The following is a description of a gene set: Nephrocalcinosis Human Gene Set: HP_NEPHROCALCINOSIS studied in species Homo sapiens Nephrocalcinosis is the deposition of calcium salts in renal parenchyma., and this is the list of marker genes: GTF2IRD1, TRNT1, MAGED2, STX1A, ATP6V0A4, BTNL2, STRADA, KCNQ1, TMEM270, TOR1A, BAZ1B, GEMIN4 (gem nuclear organelle associated protein 4), ENPP1, GTF2IRD2, CLCN5, VIPAS39, MEN1, BSND, ATP6V1B2, SLC12A1, CDC73, MLXIPL, METTL27, IFT56, HLA-DRB1, CTNS, SLC2A2, KCNJ1, SLC4A1, FUT8, PIK3C2A, STX3, GNA11, FAM20A, HSD11B2, SRP54, AIRE, ATP6V1E1, SLC7A7, CDKN1C, DYNC2I2 (NCBI Gene Id 89891), MYO5B, CASR, FAH, CLCNKA, HPRT1 (NCBI Gene Id 3251), DNAJC30, TBL2, SRCAP, CLPB, SLC37A4, RRAGD (Ras related GTP binding D), FGF23, PEX3, TBC1D24, FKBP6, RFC2, ELN, HNF4A, MPV17, CYP24A1, IGF2, CLDN16, SLC1A2, PTH1R, ADAT3, VPS33B, LIMK1, PHEX, KCNQ1OT1, AMMECR1, ABCC6, ALPL, MEFV, AGXT, GTF2I, ROR2, EIF4H, ATP1A1 (NCBI Gene Id 476), BUD23, GRHPR, VPS37D, CLCNKB, ZNF687, GATA3, GALNT3, SLC34A1, OCRL, INSR, GCM2, SBDS, OXGR1, CLDN19, PTH, NCF1, SLC34A3, POLRMT, CLIP2, COL4A3 (collagen type IV alpha 3 chain), ZFX, HOGA1, PIGT, CRELD1, DNAJC21